Given this list of marker genes Trem3, Tusc2, Card9, Lilrb4b, Ackr1, Oas1e, Trpv4, Foxp1, Sigirr, Tgfb1, Cxcl5, Chil3, Tnfsf4 (NCBI Gene Id 226545), Alox8, Usp25 (ubiquitin specific peptidase 25), Cd84, Cd24a, Ager, F2rl1, Mavs, Snai2, Cd74, Gstp3, Arg2, Ccl5, Zfpm1, Umod, Clec7a, Tirap, Myd88, Nfkbiz, Kcnn4, Aire, Mif, Oas1b, Adcyap1, Lrp1, Mapk9, Lpl, Tlr7, Chil6, Ffar3, Nr1h4, Fosl2, Il17a, Oas1h, Oas1c, Ccn1, Il7, Eif2ak2 (NCBI Gene Id 76759), Mul1, Il4, Lgals9, Slamf9, Havcr2, Pycard, Trim32, Wnt5a, Il18, Postn, Oas3, Tlr2, Hmgb1, Gstp2, Tlr9, Map2k5, P2ry2, Apod, Nod2, Tlr3, Egr1, C1qtnf3 (C1q and tumor necrosis factor related protein 3), Mbp, Aif1 (allograft inflammatory factor 1), Csf1r, Mpl, Il16, Ifng (NCBI Gene Id 15978), Adipoq, Hc, Ticam1, Tnfsf18, Oas1f, Adam17, Oas1g, Socs5, Gstp1, Il17ra, Tnf, Chil4, Gstp-ps, Elane, Tlr4, Nfkb1, Twist1, Il1b, Epha2, Lilrb4a, Ticam2, Erbin, Oas1d, Lbp, Il33, Mefv, Chia1, Adora2b, Klf4, Vps13a, Il17f, Tslp, Trem2, Defb25, Slc37a4, Ripk2, Il6, Syk, Sirpa, Il6ra, Mcoln2, Chil5, Trem1, Oas1a, Suz12, Ext1, App, Selenok, Il1rl1, Ffar2, Il4ra, here is a description of the gene set: Mouse Gene Set: GOBP_CHEMOKINE_PRODUCTION The appearance of a chemokine due to biosynthesis or secretion following a cellular stimulus, resulting in an increase in its intracellular or extracellular levels. All chemokines possess a number of conserved cysteine residues involved in intramolecular disulfide bond formation. Some chemokines are considered pro-inflammatory and can be induced during an immune response to recruit cells of the immune system to a site of infection, while others are considered homeostatic and are involved in controlling the migration of cells during normal processes of tissue maintenance or development. Chemokines are found in all vertebrates, some viruses and some bacteria. studied in species Mus musculus